Given this list of marker genes Akap9, Hsd17b4, Gata4, Flna, Ntrk1, Tcf21, Fer (NCBI Gene Id 80679), Fshr, Map7 (microtubule-associated protein 7), Ctsl, Wt1 (WT1 transcription factor), Inhba, Atrx (ATRX, chromatin remodeler), Arid4b (AT-rich interaction domain 4B), Sox3, Arid4a, Rab13, Icam1, Abcb1a, Cftr, Sdc1, Sox8, Sox9, Scx, Nr5a1, Gata1, Nr5a2 (NCBI Gene Id 52226), Gja1, Wnt4, Il1a, Fndc3a (NCBI Gene Id 76636), Dmrt1, Nr0b1, Safb2, Adrm1, Rara, Nup210l, here is a description of the gene set: studied in species Mus musculus Mouse Gene Set: GOBP_SERTOLI_CELL_DIFFERENTIATION The process in which a relatively unspecialized cell acquires specialized structural and/or functional features of a Sertoli cell. A Sertoli cell is a supporting cell projecting inward from the basement membrane of seminiferous tubules.